Given this list of marker genes Appl2, Snx33, Dock2, Dnm2, Stx1b, Ankfy1, Cav1, Nr1h2, Cdc42, Tsc2, Carmil1, Pycard (NCBI Gene Id 66824), Kcnn4, Nr1h3, Snx5, Prom2, Cln3, Mapkapk2, Ppt1, Mapkapk3, Ehd4, Actn4, Appl1, Axl, here is a description of the gene set: Mouse Gene Set: GOBP_PINOCYTOSIS species: Mus musculus An endocytosis process that results in the uptake of liquid material by cells from their external environment; literally 'cell drinking'. Liquid is enclosed in vesicles, called pinosomes, formed by invagination of the plasma membrane.